Given this list of marker genes URI1, P4HB, ARHGAP32, SLC24A2, DESI2, PNISR, GDI2, UVSSA, BPNT2, CBX3, SPON1, DERL1, MIR214, DENND4C, NID1, ACER3, BTBD19, XRCC5, CCNL1, NKTR, UBE2K, CNEP1R1, SFPQ, NSMAF, PCDH18, SEC22B (SEC22 homolog B, vesicle trafficking protein), UBR5, PCM1 (pericentriolar material 1), NPEPPS, ATRX, TM9SF2, BTF3L4, LUM, EPS15, REXO2, TRPC1, RPP14, EPB41L3, FAP, TRIO, ANKH (NCBI Gene Id 7995), MMP14, HEY1, FHL1, CTSO, KCNQ1OT1, TICAM2, NBPF14, NASP, UBL3 (ubiquitin like 3), KLF12, GOLGA8A, RABEP1, SHQ1, TPM4, KIFAP3, DCTD, AK2, SNED1, CTSZ, ITGB1, TXNIP, PDIA3, POMK, SQLE, RNF146, TRIM27, JAG1, MAP1LC3B, COG6, PALM2AKAP2, GUCY1B1, GLUD1, CALD1, SCAF4, XRN2 (NCBI Gene Id 22803), GPRASP1, CHN1, GNG2, VCAN, ZDHHC6, KDM7A (lysine demethylase 7A), QNG1, STX2, RUSC1, NREP, PUM2, MARCHF7, ZCCHC9, PCDHB10, KLHL28, ZBTB1, SLC41A2, CUL3, APP, TNRC6A, TIMM23B, ARHGEF2, IGDCC4, NEMF, SRSF7, IDI1, SEC63, RO60, DDX3X, COL6A1, CALM1, EMP1, PANK3 (NCBI Gene Id 79646), RAB2B, TSC22D1-AS1, TIA1, NEAT1, JAK1, RGS17, VCAM1, KPNB1, JMJD1C, KITLG, NCBP3, EBF1, SLC30A7 (solute carrier family 30 member 7), CNOT8, CDC5L, NPIPB13, DEGS1, TUG1, FAT3, WASF3, RASA1, CA12, PLBD1, ZKSCAN1, TCF7L2, FGFR1OP2, SLC7A6, GABBR1, SLC25A43, PURB, CDC16, BGN, DNM1, TMEM230, here is a description of the gene set: Pathways that govern stem cell (SC) function are often subverted in cancer. Here, we report the isolation to near purity of human normal mammary SCs (hNMSCs), from cultured mammospheres, on the basis of their ability to retain the lipophilic dye PKH26 as a consequence of their quiescent nature. PKH26-positive cells possess all the characteristics of hNMSCs. The transcriptional profile of PKH26-positive cells (hNMSC signature) was able to predict biological and molecular features of breast cancers. By using markers of the hNMSC signature, we prospectively isolated SCs from the normal gland and from breast tumors. Poorly differentiated (G3) cancers displayed higher content of prospectively isolated cancer SCs (CSCs) than did well-differentiated (G1) cancers. By comparing G3 and G1 tumors in xenotransplantation experiments, we directly demonstrated that G3s are enriched in CSCs. Our data support the notion that the heterogeneous phenotypical and molecular traits of human breast cancers are a function of their CSC content. studied in species Homo sapiens The '3/3 signature': genes consistently down-regulated in all three pools of normal mammary stem cells (defined by their ability to retain the dye PKH26). from publication Pece S, Tosoni D, Confalonieri S, Mazzarol G, Vecchi M, Ronzoni S, Bernard L, Viale G, Pelicci PG, Di Fiore PP (PMID 20074520) Human Gene Set: PECE_MAMMARY_STEM_CELL_DN